Given this list of marker genes Dnm2, Pde4dip, Akap9, Rab33b, Map2k2, Armh3, Rbsn, Mapk3, Stx18 (syntaxin 18), Ehd3, Camsap3, Camsap2, Map2k1, Mapk1, Usp6nl (USP6 N-terminal like), Stx5a, here is a description of the gene set: Mouse Gene Set: GOBP_REGULATION_OF_GOLGI_ORGANIZATION species: Mus musculus Any process that modulates the frequency, rate or extent of Golgi organization.